Given this list of marker genes Syp, Lax1, Sh2b2, Skap1, Blnk, Nup62 (nucleoporin 62), Sh3pxd2b, Sqstm1 (sequestosome 1), Inppl1, Ctr9, Slamf1, Rufy1 (RUN and FYVE domain containing 1), Arhgap5, Ccdc88a, Nlk (nemo like kinase), Fgfr1, Ptk2, Irs1, Siglecg, Adam10, Shcbp1, Khdrbs2, Ghr, Ptpn6, Kit, Afap1 (NCBI Gene Id 70292), Snap91, Ms4a2, Pag1, Dlc1, Khdrbs1, Syk, Dab1, Lck, Jak2, Pirb, Trpv4, Crk, Rack1, Afap1l2, Syngr3, Lat2, Dag1, Abl1 (c-abl oncogene 1, non-receptor tyrosine kinase, NCBI Gene Id 98922), Src, here is a description of the gene set: Mouse Gene Set: GOMF_SH2_DOMAIN_BINDING studied in species Mus musculus Binding to a SH2 domain (Src homology 2) of a protein, a protein domain of about 100 amino-acid residues and belonging to the alpha + beta domain class.